The following is a description of a gene set: Mouse Gene Set: GOBP_CELLULAR_RESPONSE_TO_UV_C Any process that results in a change in state or activity of a cell (in terms of movement, secretion, enzyme production, gene expression, etc.) as a result of a UV-C radiation stimulus. UV-C radiation (UV-C light) spans the wavelengths 100 to 280 nm. species: Mus musculus, and this is the list of marker genes: Polh, Poli, Ei24, Trp53, Mdm2, Pierce1